The following is a description of a gene set: studied in species Homo sapiens Human Gene Set: GNF2_CYP2B6 Neighborhood of CYP2B6 cytochrome P450, family 2, subfamily B, polypeptide 6 in the GNF2 expression compendium Neighborhood of CYP2B6, and this is the list of marker genes: HSD17B6, MAT1A, F2, CYP2C9, DCXR, SERPINF2, SAA4, CYP2D6 (cytochrome P450 family 2 subfamily D member 6), C4BPA, C8G, HRG, GCHFR, CES1, CYP1A2, CYP2E1, UPB1, HPX, ABCC6, IGFALS, F12, LCAT, FBP1, CYP2A6, PROC, APOC4, CYP27A1, ANG, ORM1, HAMP, SDS, FCN3, AGXT, TST, ASL, ORM2, RDH16, ITIH4, APOC1, HPN, SLC27A5, HGFAC, SLC22A1, CYP2B6, SERPING1, CYP2C8, APCS, HPD, TAT, NNMT